Given this list of marker genes COA8, POLG, OPA1, KIF5A, MT-ND5, MRE11, ABHD12, SCYL1, MT-TW, MT-CO2, PMP22, MT-TF, EMILIN1, VPS13D, GBA2 (NCBI Gene Id 57704), PLA2G6, PNKP, MT-ND3, FDX2, NEFL, COA3, SETX, GJB1, SACS, PHYH, XRCC1, RRM2B, MT-ND1, B4GALNT1, MT-ND4, SLC52A2, MPV17, MT-CO3, MT-ND2, MT-TH, SLC30A10, LIG3, ATP1A1, HSD17B4, SH3TC2, PDK3, RAB7A, HMBS, MT-TK, SPTLC2, ABCD1, PSAP, RNASEH1, MT-ATP6, VCP, SPG11, HADHA, DNAJC3, GALC, DNM1L, RRM1, MT-TQ, DHH, MCM3AP, VRK1, MT-TS2, GET4, NGLY1 (NCBI Gene Id 95041), PIGB, TDP1, IGHMBP2, AHCY, SLC25A46, ADA2, AFG3L2, B2M, PEX6, RPIA, MT-ND6, MPZ, CLP1, TYMP, SCO2, LAMA2, PIK3R5, GBA1, GDAP1, NEFH, CLCF1, RFC1, IARS2, SCARB2, MT-TL1, HADHB, TFG, AMACR (NCBI Gene Id 23600), PPP2R2B, VPS41, LITAF, KIF1A, AIFM1, PDYN, MME, PEX7, UCHL1, MT-CO1, IFRD1, MT-TV, here is a description of the gene set: Human Gene Set: HP_SENSORIMOTOR_NEUROPATHY Sensorimotor neuropathy studied in species Homo sapiens